The following is a description of a gene set: Short stepped shuffling gait species: Homo sapiens Human Gene Set: HP_SHORT_STEPPED_SHUFFLING_GAIT, and this is the list of marker genes: GBA1, ADH1C, PODXL, SNCAIP, MT-TT, MAPT, SYNJ1, ATXN2, TRPV4, ATXN8OS, DCTN1, COL2A1, DNAJC6, NR4A2, TBP, PRKAR1B, ATXN3